Given this list of marker genes SLC5A7, VAMP1, PLA2G6, ZNF699, CACNA1A, DNM1, AGRN, MYO9A, SLC2A3, SLC18A3, COL13A1, HTT, SLC25A1, SYT2, SCN4A, CHAT, SNAP25, here is a description of the gene set: Human Gene Set: HP_CHOKING_EPISODES species: Homo sapiens Choking episodes Incidents in which a piece of food or other objects get stuck in the upper airway and provoke coughing, gagging, inability to talk, and difficulty breathing.